The following is a description of a gene set: studied in species Homo sapiens Human Gene Set: GSE37301_COMMON_LYMPHOID_PROGENITOR_VS_RAG2_KO_NK_CELL_DN Expression profiling of Rag2-deficient Ets1++ and Rag2-deficient Ets1-- mature NK cells and WT bone marrow progenitors, WT T cells, and WT Pro B cells Genes down-regulated in common lymphoid progenitors versus RAG2 knockout NK cells. from publication Ramirez K, Chandler KJ, Spaulding C, Zandi S, Sigvardsson M, Graves BJ, Kee BL (PMID 22608498), and this is the list of marker genes: MEIS2, CCR9, LYZ, ATXN7L1, SPG11, FPGT, FXR1, C5AR1, DOCK9, CEP170, RPL24, RAB40AL, PABPC3, CCAR2, DRICH1, GNL3LP1 (NCBI Gene Id 80060), TSKS, ADRA1A (NCBI Gene Id 148), LRRN3, BTG4, SCLY, HPS4 (HPS4 biogenesis of lysosomal organelles complex 3 subunit 2), PHLDB1, TPPP3, MAX, MAN1C1, RAB13, CPE, HEMK1, COL9A2, HOXA3, TIE1, EFR3A, OPN3, RMND5B, NDUFA8, IFITM1, ARFGEF2, PPP1R1A, FAM171A1, NALF1, TMEM140, STARD7, MIEF1, ATP10A, CDH18, HMOX1, EIF3H, GRK5, CYLD, AGTPBP1, KRT34, RAVER2, APEX1, ZDHHC7, CDC40 (cell division cycle 40), DIAPH2, PNPLA4, EVI2B, TFDP3, LY96 (NCBI Gene Id 23643), ADH1B, ACVR1, EDDM3A, GUCY1B1, SMCP, SDK2, IMPACT, SUOX, SSBP2, ZNF529, CEP68, IER3, BCHE (butyrylcholinesterase), POU2AF1, CCDC70, ACAD10, PVT1, ZIC3, CA12, PMS2P5, CLIP2, PLAC8, RPS8, TBCD, GTF2E1, TPSD1, ACOX1, H4C8, FLT3, PLXNB2, NBL1, RTN2, POU2F2, CLEC11A, SELPLG (selectin P ligand), DEGS1, EIF2D, STK32B, BAZ2B, FRAS1, GNAL, RAB3GAP1 (RAB3 GTPase activating protein catalytic subunit 1), PTCD1, CEPT1, MYC, IFNGR2, TPK1, CRTAM, SCGB2A2, SHC3, ADK, KALRN, OGFRL1, DNALI1, PEAK1, TRMT1L, EIF3E, HAND2-AS1, SPAG16, LEF1, LIMS2, RIGI, PCDHGA9, PDHX, PDE1B, BACH2, SRM, KLF7, L1CAM, MKRN1, BPNT1, COL6A3, PADI2, MOBP, TBC1D8B (NCBI Gene Id 54885), DLX6, MTARC2, UBE3B, DET1, SLC2A5, TDRD12, DYSF, MBP, EP400 (NCBI Gene Id 84442), EPB41L3, TCF7, AGO2, GRSF1, USP24, KLK2, OSM, TGFB2, TP53BP2, PTK7, CD48, CCR7, SMG7-AS1, ZC3HAV1, ADCY7, BTNL8, SLC22A18AS, CTDSPL, S100A10, CDH19, ACAP2, ZEB1, CXCL5, CDC42BPA, PITPNB (phosphatidylinositol transfer protein beta), CUL2, CCL24, COQ8B, PLAAT4, SMYD3, TFEC, MAL, TNKS2, SWAP70 (switching B cell complex subunit SWAP70), APOA4, PCBP2, CAPN11, PLAC4, GGT1, LYPD3, ARHGAP15, CHFR, DPYSL2, CDKN2A, LUC7L3, SERPINB2, TOGARAM1, GEMIN6, FCER1G, ARID5B, MYO16, DMP1, RIMS1